The following is a description of a gene set: studied in species Homo sapiens Human Gene Set: AGTCAGC_MIR345 Genes having at least one occurence of the motif AGTCAGC in their 3' untranslated region. The motif represents putative target (that is, seed match) of human mature miRNA hsa-miR-345 (v7.1 miRBase)., and this is the list of marker genes: IQCK (IQ motif containing K), SPRED2, ZMYM5, PCBP2, SLC25A12, KIF1B, ZFAND3, LRRC15, FAM168B, NXPH1, ZFC3H1, RNF111 (NCBI Gene Id 54778), SOCS4, CACNB2, ZNF609, PAPOLA, UTP14C, LSM14A, ARL8B, OGA, ARL3, SMARCA1, SCMH1, SLC25A26, ZBTB8A, PFKFB2, PRRC2C (NCBI Gene Id 23215), EPS8, LIMD2, KLF9, HACD2, UBFD1, FAM76B, BIRC6, CMIP, RAB5C (NCBI Gene Id 5878), DYNC1LI2, SRSF5, FNBP1L, RAB37, SMS, PTGES3, DMC1, ABCD3, CPEB2 (NCBI Gene Id 285549), NFIA, LSM12, ATP2B3, CDV3, UBE2H, RBMS3, PRPF3, VAT1L, E2F3, ANXA11, GLS2, SSBP2, UBAP2, FBXO33